The following is a description of a gene set: Abnormality of the cervical spine Any abnormality of the cervical vertebral column. Human Gene Set: HP_ABNORMALITY_OF_THE_CERVICAL_SPINE studied in species Homo sapiens, and this is the list of marker genes: FLI1, CDH11, PIGA, RYR1, UFD1, FANCI, DLK1, ERCC1, NBN, SMAD4, MED12, PIEZO2, LFNG, CHRND, BPTF, SCN4A, SATB2, TAF1, MRPS28, LMOD3, GDF3, CD247, KCNN3, SPRED2, POGZ, CFL2 (cofilin 2), LIFR, MEGF8, ALG9, DDR2, TFAP2A, TXNDC15, MGAT2, HBA2, AMMECR1, RFX7, EXTL3, UNC80, GABRA3, CLP1, LHX3, TRIP11, PTCH1, KRAS, BGN, DOK7, DPYSL5, NXN, FUCA1, DHCR24, KNSTRN, ARSL, TBX6, CTDP1, TBR1, HIRA, TPM2, AIFM1, BBS10, STX16, INPPL1, PGAP1 (post-GPI attachment to proteins inositol deacylase 1), SCAPER, DDRGK1, SMPD4, CHRNA1, TRAPPC9, BBIP1, TOR1A, MED13L, ACTB, RAB23, COL2A1, MAPK1, MSL3, GLB1, DHCR7, KIF7, HECTD4, MADD, ATP6V1B2, HRAS, FZD2, GJA5, OBSL1, GMPPB, CHRNG, PRMT7, RPL35, ERMARD, MECP2, B3GALT6, ARL6, TBL1XR1, WNT4, SLC35D1, BBS2, WNT5A, RIT1, NIPBL, HBA1 (NCBI Gene Id 3039), RPS20, SOX9 (NCBI Gene Id 6662), PIGL, RPS17, RMRP, FOXA2, IDUA, TNNI2, FLNA, FN1, TCF4, POMT2, MESP2, CLDN11, FILIP1, HES7, RB1, APC, RPS15A, CDK5, EXOSC9 (exosome component 9), ANTXR2, COMT, ZC4H2 (zinc finger C4H2-type containing), HNRNPR, OTUD6B, PIGO, C2CD3, RPS26, AHDC1, PLCB4, PPP1R15B, RDH11, FANCB, TECPR2, INTS1, TMCO1, RPL11, PGAP3, POU1F1, GPX4, PLAAT3, HDAC4, MPL, DONSON, GNPTAB, MAN1B1, SEC24C, BBS4, DVL3, ANKRD55, COL11A2, SHOC2, TIMM50, B3GLCT, GDF6, KIF26A, GPC3, GPC6, GPC4, DDX3X, GJA8, H4C5, FGD1, PTPN11, POMT1, BRF1, TRMT10A, IFT27, RPS28, BRAF, COL6A2, SLC26A2, GATA4, RPL31, ACTG1, RFT1, FTO, NANS, RPL26, GP1BB, LARGE1, SDCCAG8, CD96, PTPN2, PIGV, ADA2, ERCC5, NOTCH2, PUF60, CEP290, RIPPLY2, FGFR2, MUSK, EP300, WWOX, SCYL2, INTU, VPS33A, DPYD, JMJD1C, GNPTG, FGFR3, ARVCF, CHN1, TBX15, SNRPN, TGDS, BBS9, KIFBP, FAM20C, ESCO2, SALL4, PTPN22, NAA10, FREM2, SMAD3, STXBP1, RPL15, THPO, NRAS, CUL4B, SRCAP, SOS1, TBX2, SRRM2, EBP, IFT140, VPS35L, COG8, EFNB1 (ephrin B1), DCC, GNS, RPS27, NEB, TUBB, GPKOW, LAMA5, GALNS, BBS5, PAM16, SCLT1, PALB2, HEATR3, RNU4-2, AEBP1, IFT74, DLL3, BBS12, ALG8, NKX3-2, TGFB3, TBCK, IFT172, SLC35B2, BUB1B (BUB1 mitotic checkpoint serine/threonine kinase B), FBN2, CFAP418, WAC (NCBI Gene Id 55468), GNAS, CHST14, DYRK1A, TRPV4, TRAPPC2, FGFR1, MAPRE2, AP5Z1, GZF1, SOS2, CTNND2, MKKS, SEMA5A, IDH1, RSPRY1, LMX1B, FKRP, PIGY, CUL7, RIPK4, LZTFL1, CBL, HPDL, TCTN2 (tectonic family member 2), NOTCH3, YWHAE, ABCC9, MYH3, NEK9, GLE1, GLI2, ACTA1, TRIM32, MAFB, EXOC6B, COL6A3, PIK3CD, RPS24, LHX4, BRD4, SPRED1, NLRP1, ACAN, CCN6, WASHC5 (NCBI Gene Id 9897), RTL1, WDPCP, PROP1, ECEL1, RPS29, PIGW, COG5, MYL11, PSAT1, ROR2, COL6A1, NALCN, EMD, RPS19, PSMD12, CEP19, SMS, LZTR1, RPL35A, RNU4ATAC, IL2RB, TALDO1, COL11A1, RAB5IF, SMARCAL1, BBS7, ERCC2, CSGALNACT1, SMC3, MAB21L1, GATA1, PAICS, MRPL12, MYO18B, HSPG2, ROBO3, MAP2K2, BBS1, KCNH1, STAT4, TRPM3, PIGN, KIAA0586, NR4A2, RREB1, FANCL, RPL8, IGBP1, GNPNAT1, RPS7, TRAF7, XYLT2, TAF6, RAB33B, NPHP1, IL6ST, TAPT1, RAD21, TBX5, PAFAH1B1, HSPA9, CCDC8, POLR3A, PLXNA1, PPP1CB, TTC8, HNF1B, SHOX, HTRA1, RPL18, SLC2A1, RAF1, HDAC8, CCDC22, IL2RA, AFF3, MEOX1, ADAT3, NUP188, POP1, RPS10, TSR2, KCNJ8, KLHL41, BAP1, SMC1A, RPL5, CHST3, B3GAT3, GUSB, MAP2K1, MICU1, TBX1, RPL27, XYLT1, TNNT3, NBAS, ASCC3, COMP (cartilage oligomeric matrix protein, NCBI Gene Id 5659), OTX2, CREBBP, HS2ST1, PGAP2, WDR35, NUP88, MKS1, POLE, COL12A1, SETBP1, ATRX, PKDCC, IDS, SF3B4, FHL1 (NCBI Gene Id 2273), UBE2A, DYM, RPL9, PHGDH, COG1, COG7, CANT1, ERCC6, HESX1, SKI, DHX37, CRLF1, FLNB, DSE, ANKRD11, CEP55, ALDOA, MEG3, MAN2B1, DVL1, TGFBR1, BMPER, MMP2, NF1, WNT7A